Given this list of marker genes ADIPOQ, DUSP7, DEFB114, AIDA, SERPINB3, HIPK3, PTPRJ, CD300A, RGS14, APOE, CDK5RAP3, DNAJA1, PTPN22, PDCD4, PAQR3, PTPN1, AGT, MAPK8IP1, LYN, STK38, NPPA, DUSP1, here is a description of the gene set: Any process that stops, prevents, or reduces the frequency, rate or extent of MAP kinase activity. Human Gene Set: GOBP_NEGATIVE_REGULATION_OF_MAP_KINASE_ACTIVITY studied in species Homo sapiens